Given this list of marker genes CD244, HHIP, DAPK1, ITPR1, MUC13, DMTF1, RSPO4, RHBDL3, RTN4RL1, ATXN7L3B, ABHD14B, RC3H1, ENTPD4, TACC2, TMEM176A, CLCN3, IL1R1, CD47, LRSAM1, CGAS, PACS1, PRR14L, CIRBP, PROP1, ZNF397, WNK1, NBEAL2, TEF, NRIP1, CAMKK2, SPHK1, TFDP2, CD27 (CD27 molecule), CISH, MED13L, KCNJ2, CD33, NLRP3 (NLR family pyrin domain containing 3), ATP7A, LRFN1, PPARD, ABHD4, CUX1, ITSN1, RNF144A, SNHG7, GAB3, RNF38, SLA2, REEP3, TBC1D2B, PISD, ATOSA, FLT3, EPB41L3, ADGRG3, PLXNC1, TUT7, MED1 (mediator complex subunit 1), TET1, CCDC93, F2R, FLCN, APCDD1, CIPC, KIAA0930, CCND1, IL27RA, HS1BP3, ARRDC2, AQP9, RNF213, TMEM268, TYK2, CTNND2, SPNS3, GIMAP8, ESR1, INSR, PSD3, CENPV, PAN3, RESP18, STK10, OSBPL5, ADCY7, ABCA1, GBP6 (NCBI Gene Id 163351), CX3CR1 (NCBI Gene Id 2836), DOCK5, BASP1, TNFRSF1A, MFAP3, C2orf88, FAM78A, SLC25A36, MYO18A, HCN1, MAP3K11, URI1, PALD1, RUNX2, MACROH2A1, TUBB6, TBX15, ITIH5, SLC43A2, KIF21A, TBXA2R, CCR9, TRPT1, ERICH3, FADS6, SHISA5, ZBTB48, ABTB3, CDS1, SEMA4D, RSPH3, NKG7, ILDR2, RHOBTB3 (Rho related BTB domain containing 3), HLA-DOB, RBM26, IGF1R, CHST15, TFCP2, KCNK16, PLCL1, MNT, APPL2, PRR36, FYB1, OPA1, MYH1, HLA-B, RSAD2, KAZALD1, CD34, SELPLG, MSI2, PELI2, CEP350, EPOP, KBTBD11, SLIT3, TSC22D1, SYTL1, ABCC1, APCS, CARD6, SDR42E1, ZGRF1 (NCBI Gene Id 91431), KDM5B, ZYX, TTC3, SLC38A2, MAP3K20 (mitogen-activated protein kinase kinase kinase 20), CRTC1, CDK19, TBC1D16, TBX6, BLTP3A, DHX30, LZTS2, RAI1 (NCBI Gene Id 6600), JDP2, ZMYM3, PAOX, C1orf198, TYROBP, ERN1 (endoplasmic reticulum to nucleus signaling 1), ATF7IP, TBL1XR1, SH2D5, IRAK1, SLC25A53, BCL2L11, CNTN2, NDP, SLC2A9, NOTCH2, ARHGEF4, BAZ2A, ELP2, HHIPL1, WDR13, BMF, ELK3, SLC38A1, ABI2, ITGAL, MAPKAPK3, SLC41A3, BCL2, CHDH, BMP2K, ARHGEF18, RPS6KA1, NAT8L, here is a description of the gene set: from publication Aujla SJ, Chan YR, Zheng M, Fei M, Askew DJ, Pociask DA, Reinhart TA, McAllister F, Edeal J, Gaus K, Husain S, Kreindler JL, Dubin PJ, Pilewski JM, Myerburg MM, Mason CA, Iwakura Y, Kolls JK (PMID 18264110) Genes up-regulated in primary bronchial epithelial cells: control versus stimulated with IL22. Primary HBE cells were stimulated with IL-22 and IL-17, and gene expression was studied using an Affymetrix platform microarray, in order to investigate which genes may be upregulated or downregulated in response to these cytokines. Of particular interest was the host defense genes such as antimicrobial peptides, which have been shown to be upregulated by IL-22 and IL-17 in skin keratinocytes. studied in species Homo sapiens Human Gene Set: GSE10240_CTRL_VS_IL22_STIM_PRIMARY_BRONCHIAL_EPITHELIAL_CELLS_UP